The following is a description of a gene set: species: Mus musculus O-linked glycosylation Mouse Gene Set: REACTOME_O_LINKED_GLYCOSYLATION, and this is the list of marker genes: Pomgnt1, Sspo, Galnt7 (NCBI Gene Id 26911), St6galnac2, Adamtsl5, Adamts19, B3gnt3, Muc20, Galnt1, A4gnt, B3glct, Muc5b, Gcnt7, Galnt5, St3gal1, Galnt4, Muc16, Adamtsl4, Adamts18, Fut10, Pofut2, Muc13, Galnt17, Adamts17, Mmrn2, Adamts12, Adamts2, Cfp, B3gntl1, Thsd7b, St3gal2, Pomt1, Gcnt3, St6galnac3, Adamtsl2, Large1, St3gal3, Muc19, Fut11, Galnt11, Thsd1, Galnt18, C1galt1c1, Galnt15, B4galt5, Adamts3, Dag1, B3gnt7, Adamts15, Thsd7a (NCBI Gene Id 671480), Adamts13, Muc17, Adamts9, Muc2, B4gat1, Muc4, Large2, Thbs2, Galnt12, Galnt3, Chst4, B3gnt2, Adamts8 (ADAM metallopeptidase with thrombospondin type 1 motif 8), B3gnt4, Galnt6, Adamts4, Adamts14, Thbs1 (NCBI Gene Id 21825), Galnt2, Thsd4, B4galt6, Spon1, Emid1, B3gnt8, Gcnt4, B3gnt5, Spon2, B3gnt9, Sema5a, Galntl6, Muc21, Pomt2, Galnt16, Galnt13, Adamts6, St3gal4, Adamts5, Pomgnt2, Mmrn1 (multimerin 1), Gcnt1, Galnt14, C1galt1, St6galnac4, Adamtsl3, B3galnt2, Adamts20, Muc15, B3gnt6, Galntl5, Adamts16, Adamts7, Muc1, Muc5ac, Adamtsl1, Muc6, St6gal1, Adamts10, Sema5b, Galnt9, Sbspon, Galnt10, Adamts1, Pomk